The following is a description of a gene set: Catalysis of the reaction: S-adenosyl-L-methionine + a histone H3 = S-adenosyl-L-homocysteine + a methylated histone H3. Histone methylation generally occurs on either an arginine or a lysine residue. studied in species Homo sapiens Human Gene Set: GOMF_HISTONE_H3_METHYLTRANSFERASE_ACTIVITY, and this is the list of marker genes: SMYD5, SMYD3, SUV39H2, SETBP1, PRDM7, MECOM, SETD2, SETDB2, SETD1A, CARM1, SETD3, SMYD1, PRMT5, KMT2D, SMYD2, ASH1L, KMT2C (NCBI Gene Id 80260), SETD7, PRMT2, SETMAR, KMT2A, PRDM8, WDR5, KMT2E, PRDM9, SETD4, JARID2, EZH1, METTL23, NSD3, SETD1B, SETD5, SUV39H1, KMT2B, SETDB1, NSD1, DOT1L, EZH2, PRDM16, EHMT2, EHMT1, PRDM2, PRMT6, NSD2